Given this list of marker genes SLC7A6, ITGA6, ITGA3, ATP1B3, ITGB1, SLC7A5, SLC3A2 (solute carrier family 3 member 2), L1CAM, SLC7A7, ATP1B1, SLC7A10, SLC16A8, BSG, SLC16A3, SLC7A8, SLC7A9, PPIL2 (NCBI Gene Id 23759), MAG, CAV1, SPN, PPIA, MMP1, ATP1B2 (ATPase Na+/K+ transporting subunit beta 2), SLC7A11, SLC16A1, here is a description of the gene set: Basigin interactions Human Gene Set: REACTOME_BASIGIN_INTERACTIONS species: Homo sapiens